Given this list of marker genes RNASEK, ATP6V1A, ATP6AP2, ATP6V1D, ATP6V0B, UBE3A (NCBI Gene Id 7337), SLC9A7, SLC9A8, ATP6V1F, ATP6V0A2, ATP6AP1, ATP6V0C (ATPase H+ transporting V0 subunit c), ATP6V1H, here is a description of the gene set: Human Gene Set: GOBP_GOLGI_LUMEN_ACIDIFICATION Any process that reduces the pH of the Golgi lumen, measured by the concentration of the hydrogen ion. species: Homo sapiens